The following is a description of a gene set: species: Homo sapiens Any process that stops, prevents or reduces the frequency, rate or extent of cell maturation. Human Gene Set: GOBP_NEGATIVE_REGULATION_OF_CELL_MATURATION, and this is the list of marker genes: EDNRB, SHB, WEE2, TBX6, PAEP, BCL11A, NPPC, NPR2